Given this list of marker genes Fgfr2, Hmga2, Shc1, Fgfr3, Lef1, Pth, Il6, Mef2c, Mir223, Flt3l, Map3k3, here is a description of the gene set: A process that activates or increases the frequency, rate or extent of cell proliferation in the bone marrow. species: Mus musculus Mouse Gene Set: GOBP_POSITIVE_REGULATION_OF_CELL_PROLIFERATION_IN_BONE_MARROW